The following is a description of a gene set: studied in species Homo sapiens Human Gene Set: GSE2585_THYMIC_DC_VS_THYMIC_MACROPHAGE_UP from publication Derbinski J, Gäbler J, Brors B, Tierling S, Jonnakuty S, Hergenhahn M, Peltonen L, Walter J, Kyewski B (PMID 15983066) Gene expression in different thymic stromal cells and subsets thereof was analyzed in 6-12 week old wild type (C57BL/6) and Aire knock-out (mixed background) mice. Thymic stromal cells were purified by sequential enzymatic digestion (collagenase, collagenase/dispase and trypsin) followed by gradient centrifugation and FACS sorting. Sort criteria were as follows: dendritic cells (CD11c+, F4/80 -), macrophages (F4/80+, CD11c-), cTECs (CD45–/lo, CDR1/Ly51+, Ep-CAM+) and mTECs (CD45–/lo, CDR1/Ly51–, Ep-CAM+). mTECs of wild-type and Aire knock-out mice were further subdivided according to CD80 expression levels. For microarray analysis total RNA from thymic stromal cell samples of two independent experiments was pre-amplified and biotinylated by two rounds of cDNA synthesis and in vitro transcription. Fluorescence readings were evaluated by using Microarray Suite 5.0 software. Genes up-regulated in thymic: dendritic cells versus macrophages., and this is the list of marker genes: SLC34A1, AGTR1, CYP11B1, MYBL2, SPINT3, CYP7B1, GPX7, ITFG1, TPD52L2, SH3BP2, MFAP5, DAZL, NUDT11, EBLN2, TUBB4B, MAN2C1, TRIB1, CORO7, LRRC31, LDB2, AURKAIP1, WDR33, SLC34A2, CDX1, DMD, S100A8, TRAF3IP1, EPCAM, KLF3-AS1, FABP6, ENSG00000237250, DIABLO, MT1M, SLC25A20, IRS1, GUSBP14, SLC23A2, AFDN-DT, IFNAR1, CKAP5, SCAND1, RGS17, FAM174B, PIK3CG, ADGRL2, AP1B1, FMO1, LRP4, TP53TG1, PYCR3, PLA2G15, GALNT12, RMND5B, KRTAP9-9 (NCBI Gene Id 85279), CYBRD1, LILRP2, XCL1, ATF5, COX4I1, ANKRD13C-DT, FKBPL, NUTF2, ADAMTS9, NHERF1, SYT13, LZTR1, BHLHE40, NMBR, MTMR14, H2BC6, OMG, NUDT21, ECM2, SLC1A2, TRAV12-2, CHM, NRL, ATP5MC2, IFT70A, GRHPR, MFAP2, ACSBG1, NR0B1, RAP2B, HTR1F, ANGPTL7, IKZF2, TMUB2, SLC6A15, CLDN18, CD52, TEAD1, RAB35, H3C11, F5, PTPN3, SLCO3A1, SLC5A4, KRT76, UBIAD1, H2AC14, BIN1, SPAM1, SULT1C2, KLRD1, CCNYL7, MYH8, KIR2DS2, ZNF217, RC3H2, RABAC1, TOR1AIP1, PEX11A, POM121L2 (NCBI Gene Id 94026), RNF19B, UBL3, TTC12, JCAD, SERPINB3, HOXB8, VIPR1, OBSL1, GP5, CDK14, MAP2, ACTN4, PTGFR, ANGPT4, QDPR, ZWILCH, NEK11, APOBEC3F, SLITRK5, POLA2, AKR1A1, NPR2, PTCH1, SH2B2, CTAGE11P, FBXL15, RNF2, CEL, RPL3, ZKSCAN8, RRP7A, ATP6V0A1, PEX6, SARS2, NFATC1, ARFIP2, RIC3, REG3A, CPB2, TMPRSS6 (NCBI Gene Id 164656), SLC22A1, COL2A1, TUBGCP5, VPS35L, FAM168B, ARHGEF9, ZNF35, NMUR1 (neuromedin U receptor 1), CDR1, PTPRB, RNF32, DDX49, BCAP31, PMS2P5, KRTAP2-4, RSAD1, ID3, TMEM127, SGSM3, H3C6, C14orf132, BMAL2, ZNF652, DIAPH2, RELA, SLC22A4 (NCBI Gene Id 6583), FOXN3, CRLF2, KCNE5, ORM1, MIA3, R3HCC1, PTTG1, NMB, FANCC, ECHDC3, IFNA2, SREBF1, MED25 (mediator complex subunit 25), EIF5A2, SUPT3H